Given this list of marker genes Stard4, Gnai1 (NCBI Gene Id 14677), Gpr146, Lpcat3, Fgf1 (NCBI Gene Id 14164), Sod1, Mbtps2, Ces1b, Ces1h, Dgat2, Acadvl, Qki, Insig1, Pex2, Dgkq, Cyp7a1, Gnb3, Fdps, Arv1, Acadl, Mapk1, Sec14l2, Apoa1, Ces1e, Apob, Apoe, Dhcr7, Npy1r, Abcg4, Prkaca, Abcg1, Ces1f, Ttc39b, Fmo5, Ephx2, Ces1d, 3110082I17Rik, Thrb, Ttc39d, Scap (NCBI Gene Id 94123), Scp2, Lmf1, Ces1g, Paqr3, Erlin2, Idi2, Serpina12, Ch25h, Erlin1, Ces1c, Srebf1, Ces1a, Ldlr (low density lipoprotein receptor), Aqp8, Por, Srebf2, here is a description of the gene set: Any process that modulates the rate, frequency, or extent of cholesterol metabolism, the chemical reactions and pathways involving cholesterol, cholest-5-en-3 beta-ol, the principal sterol of vertebrates and the precursor of many steroids, including bile acids and steroid hormones. Mouse Gene Set: GOBP_REGULATION_OF_CHOLESTEROL_METABOLIC_PROCESS species: Mus musculus